Given this list of marker genes Gfpt2, Ppat, Cad, Ucp2, Pfas (NCBI Gene Id 237823), Gls2, Gls, Slc38a1, Nit2, Phgdh, Sirt4, Bloc1s6, Glul, Nr1h4, Cps1, Lgsn, Asl, Mecp2, Glud1, here is a description of the gene set: Mouse Gene Set: GOBP_GLUTAMINE_METABOLIC_PROCESS The chemical reactions and pathways involving glutamine, 2-amino-4-carbamoylbutanoic acid. species: Mus musculus